The following is a description of a gene set: studied in species Mus musculus The evagination of a membrane, resulting in formation of a vesicle. Mouse Gene Set: GOBP_VESICLE_BUDDING_FROM_MEMBRANE, and this is the list of marker genes: Trappc1, P2rx7, Anxa2, Dnm3, Golph3, Arfgap3, Arf1, Picalm, Sec31b, Tmed10, Rilp, Wasl, Cideb, Trappc4, Sar1a (secretion associated Ras related GTPase 1A), Sec24d, Tmed10-ps, Ap3d1, Prkci (NCBI Gene Id 99620), Ap3m2, Sec24b (NCBI Gene Id 99683), Trappc9, Trappc6a, Dnm2, Btbd8, Trappc6b, Sec23a, Mapk15, Golph3l, Tbc1d20, Myo18a, Pef1, Trappc5, Chmp5, Vapb, Chmp4c, Trappc11, Chmp7, Prkn, Rab1a, Surf4, Chmp6 (NCBI Gene Id 69715), Mia3, Sar1b, Sec16a, Trappc2, Trappc2l, Arfgap2, Trappc12, Ap3b2, S100a10, Pdcd6, Tmed9, Vapa, Gbf1, Fsip1, Klhl12, Sec24a, Sec24c, Trim72, Ap3s2, Chmp4b, Cul3, Mx2, Ap2m1, Ap1s2, Insig1, Preb (NCBI Gene Id 97258), Scap, Slc2a4, Snap91, Sec23b, Fnbp1l, Sec13, Ap3s1, Trappc3, Sec31a, Trappc10, Trappc13, Vps4a, Snx3, Dnm1